The following is a description of a gene set: species: Mus musculus Any process that activates or increases the frequency, rate or extent of the neurotrophin TRK receptor signaling pathway. Mouse Gene Set: GOBP_POSITIVE_REGULATION_OF_NEUROTROPHIN_TRK_RECEPTOR_SIGNALING_PATHWAY, and this is the list of marker genes: Tmem108, Cyfip1, Ngf, Wasf1, Ppp2r5b, Ppp2r5d, Sh3glb1, Cyfip2